The following is a description of a gene set: species: Homo sapiens Human Gene Set: GOMF_PROLINE_RICH_REGION_BINDING Binding to a proline-rich region, i.e. a region that contains a high proportion of proline residues, in a protein., and this is the list of marker genes: GIGYF2, APBB1, BAIAP2, PFN1, YAP1, RABAC1, CTTN, CYLD, ABI2, ABL1, NEDD4, ITSN1, BAIAP2L1, CCND1, GHR, SH3D19, GAREM1, WBP4, CSK